Given this list of marker genes TSPAN13, ABHD5, CAMK1D, CDK2AP2, TGFB2, BMP3, TIPARP, HSPA12A, TNNI1, USP25, KDM6A, TPBG, DUSP23, ASXL3, HIC2, RAB33A, CDV3, BNIP1, MYCN, LAMA3, RASSF7, TCEAL5, ZMIZ1, KLK5, TMEM106C, CAP2, SPECC1, AMHR2 (anti-Mullerian hormone receptor type 2), TP53RK, DICER1, RNF141, KIAA1217, ADARB1, SCG5, TSTD1, TRAF3IP2 (NCBI Gene Id 25997), FBXL7, MYEF2, ADAM15, NXPH2, PLCXD1, SVIL, ADAMTS9, GKAP1, KREMEN2, HNRNPA1L3, ABHD8, AMOTL2, PEG3, FRAS1, RSPO1, COL26A1, PLEKHN1, SIGIRR, TCEAL2, ZNF738, NDST3, EPHA7, PAPPA, PLEKHA8, AGAP1, AJUBA, C1GALT1, ZFR2, FZD6, MLLT1, WT1, SMTNL2, NXN (NCBI Gene Id 64359), PDHX, LRRTM1, IER5L, RSPO3, ECHDC2, NET1, MYRF, PARM1, CCDC186, SULF2, ABCC1, CFC1B, MIEN1, TSPAN2, EMC9, CADM2 (cell adhesion molecule 2), SMAD6, CXXC5, CFC1, TUBB2B, MAMSTR, FLRT3, LIN7B, ZDHHC12, PAK4, TMEM178A, AGPAT2, GALNT9, TBC1D22A, STRBP, TNFAIP8L3, EPHA3 (NCBI Gene Id 2042), RCHY1, RAB11FIP1, DOCK11, COL11A1, PIM3, PTPN18, UBTD1 (ubiquitin domain containing 1), GPM6A, BNC2, SEC11C, H2AC25, PICK1, PACC1, TNNT2, GPRC5A, GOLGA8B, RHOU, TDRP, PLP2, JOSD1, DMKN, FAAH, CLUL1, COBLL1, GDE1, CMYA5, LRATD2, NPNT, PODXL, CNTN4, GABRA2, SH3BP5, NFE2L3, IGSF9, NAA40, EDN3, FZD3, NMU, ARHGAP29, OCIAD2, GRB7, SOX6, DPP3, CYFIP2, EPS8L1, VAMP8, CCDC122, CFAP68, RAB3C, WFDC2, LRRN4, TOM1L1, KCNIP1, RGS10, TUBB4A, FXYD7, DNAJC22, SLC13A3, DIPK1A, PPP3CA, PDGFC, CTXN1, CCND3, SINHCAF, MIR99AHG, LRRC61, FENDRR, GABARAPL1, SLC39A10, AP1G2, MAP3K1, TST, RDH10, MAGI2, CCDC74B, OLFML2B, FGF9, TMEM235, ADAMTS5, SLC25A4, GPRC5D-AS1, SETD9, SH3GLB2, PAWR, ECHDC3, TMEM132A, DERL3, NPW, HMCES, UPK3B, MMP11, HHIP, ALDH1A2, LINC00842, IL6R, UBE2H, TOX, AGRN, TM7SF2, TM4SF1, GNB5, TRAF4, GCA, AEBP2, SERTAD2, RTN4R, ANKRD29, HPGD, ANKRD13B, SLC2A1, ACTC1, ZNF219, BID, DAG1, ZNF467, CACNB3, DOK6, ADAM33, AATF, WNT2B, RHPN2, CRLS1, WIPF3, CSRP2, NRBP2, TOMM34, FSTL3, B9D1, HOXA4, FLNC, CADPS2, PDGFRL, KHDRBS2, LINC01003, CCDC112, PLA2G15, REEP1 (NCBI Gene Id 65055, receptor accessory protein 1), AIF1L, GJA1, PSMG4, APLP1, SLC25A29, ASS1, NUDT11, PTPRF, LRP2, CDON, CBX8, CHST3, XIST, HSBP1L1, GALE, PATJ, TRAPPC6A, ADO, EFNA1, HMGA2, NCCRP1, PRKCI, P3H2 (prolyl 3-hydroxylase 2), TSPAN7, GATA6-AS1, ARRDC1, EPS8L2, LGALS8, PLCL1, FBXL2, PHYHIPL (phytanoyl-CoA 2-hydroxylase interacting protein like), FLNB, KCNN1, RIMS1, YARS1, NHSL3, SULF1, SLC25A33, SOS2, DIRAS3 (NCBI Gene Id 9077), GLS, PARD6B, EPHB2, SBSPON, CRACR2B, FAM174B, TEKT3, DHRS3, NSG1, CADM4, SPRR2F, ST6GAL2, C15orf61, HAGH, DDR1, GXYLT1, POMGNT2, ERBB4, JUP, GIT1, COL2A1, SYNGR2, RICTOR, NUDT14, FCHO1, SYTL1, NPDC1, CDC34, CHST9 (carbohydrate sulfotransferase 9), UNC5B-AS1, KRT8, GPT2, MYL7, NAT14, GAS6, TECRL, NOL4L, IGFBP2, CD320, DBP, FKBP1B, NLN, RALGPS2, ARL4A, ASPHD1, LMNB1, GNPTAB, PODXL2, PCYOX1L, TMUB1, SORBS2 (NCBI Gene Id 8470), LEPROTL1, PYGM, ARL8A, SEZ6L2, ST6GAL1, PLPPR3, ASH2L, ZNF579, PAPLN, CD47, DNAH14, RFK, ATF7IP2, PALS1, TMEM37, CISD1, PTPRU (NCBI Gene Id 10076), TPD52L1, CTSH, SLC4A2, LAMA5, MTHFD2L, ITGA3, SEMA3B (semaphorin 3B), ARHGAP22, KPNA2, COLGALT2, EFEMP1, CRB2 (NCBI Gene Id 286204), LINC00665, CD74, GET4, NUDT10, B3GALT6, HOXC4, DHCR7, TSEN15, SPMIP5, PRKAR1B, STIM2, RAB6B, HVCN1, RAMP1, PLEKHA1 (NCBI Gene Id 59338), SIRPA, GTF2IRD1, RGS5, PTGS1, FBN3, RNF8, ALPL, CERS4, TNNI3, DPP4, CPLX1, BDNF, IGLON5, SLITRK4, CBR4 (NCBI Gene Id 84869), COL4A6, NEDD4L, REC8, DLG2, CRABP2, DEDD2, KRT18, CLDN15, CYRIB, LRP8, SYNPR, UQCRHL, FAM241B, PNPLA4, SH3BP4, BICDL1, MPPED2, DHCR24, SIPA1L2, WASF1, AFDN-DT, SMOC2, TMX4, STK33 (serine/threonine kinase 33), LINC02381, SPOCK2, CPNE2, TES, HMGA1, KRT19, SERPINB9, TMEM151A, NINJ1, SLC19A1, ST6GALNAC3, METTL21A, GASK1A, EFNA4, SPINT2, TLCD4, TRNP1, CDC42EP3, PLLP, ADH1C (NCBI Gene Id 126), SLC7A7, THNSL2, HRH2, VPS37C, NRXN3, EPHA2, NSUN7, RNF207, SNCAIP, PKP2, DSP, SPR, CDK20, TK1, FAM110C, TAF10, GATA4, LINC02482, PRKAA2, CFI, HOOK1, CD24, FREM2, BICD1, C15orf39, EFHD2, NELL2, MPV17L2 (MPV17 mitochondrial inner membrane protein like 2), HACD1, KLF5 (NCBI Gene Id 688), BEX2 (NCBI Gene Id 84707), PDLIM4, IQCA1, RPRM, IMMP2L, SLC2A11, LSR, ORC6, ZNF174, FAM221A, CXADR, SERGEF, PDXK, TOLLIP, CSDC2, FKBP11, CA11, VPS13A, PCLO, FAM171A2, STX11, C16orf87, PITPNC1, NCKIPSD, STRADB, LRRN1, MAG, COL9A3, HHIP-AS1, MEIS2, FZD2, UCHL1, DSG2, TNFRSF12A, CYP26B1, MN1, PDPN, EHD4 (NCBI Gene Id 30844), TMEM88, ZNF846, SMPDL3B, PHF13, HOXC5, LGALS2, KCMF1, GLIS2, PCAT6, ITLN1, FDXR, PLCE1, MID1, LINC01023, MCRIP2, LTC4S, PERP, WWC2, RHOD, GYG2, TNNT1, GPRC5C, SH3RF1, CDH2, ASPG, LIN7A, FUCA1, YDJC, PRKCZ, ZFPM2, ITM2A, CCDC85C, MAPRE3, TEAD4, GADL1, OLFM2, ZNF354A, SLC48A1, EDEM2, RND1, LY6H, AFDN, NHSL1, PPP1R16A, RAB38, BNC1, CA2, CAVIN2, SLC35G1, PLCB1, EFNB2, BCAR3, SVIP, GAL3ST3, SLC38A1, GSDME, FZD4, PLXNB1, SLC16A3, SHTN1, COL18A1, HAS1, MACROD2, DISP1, MAGI1, CDH3, ALCAM, EFNB3, STK26, PNMA8A, SMIM1, CCDC74A, BEX1, ABRACL, ARL4C, BAIAP2 (NCBI Gene Id 10458), ANK3, AAGAB, SLC22A5, RNASE1, FOXP4, CPZ, NEO1, CDK5, here is a description of the gene set: species: Homo sapiens from publication He P, Lim K, Sun D, Pett JP, Jeng Q, Polanski K, Dong Z, Bolt L, Richardson L, Mamanova L, Dabrowska M, Wilbrey-Clark A, Madissoon E, Tuong ZK, Dann E, Suo C, Goh I, Yoshida M, Nikolić MZ, Janes SM, He X, Barker RA, Teichmann SA, Marioni JC, Meyer KB, Rawlins EL (PMID 36493756) Human Gene Set: HE_LIM_SUN_FETAL_LUNG_C0_EARLY_MESOTHELIAL_CELL Early mesothelial